The following is a description of a gene set: Mouse Gene Set: REACTOME_GLI3_IS_PROCESSED_TO_GLI3R_BY_THE_PROTEASOME species: Mus musculus GLI3 is processed to GLI3R by the proteasome, and this is the list of marker genes: Psmc1, Ubc, Rbx1, Psmc5, Uba52rt, Psmd11, Psmc3 (NCBI Gene Id 19182), Psmd2, Psmb4, Psma2, Psmd14, Skp1, Psmb1, Psmd6, Psmd13, Ubb, Csnk1a1, Psmb6, Psmb2 (proteasome (prosome, macropain) subunit, beta type 2), Psmc6, Psmd8, Prkacb, Psmc4, Psma4, Psma6, Psmd1, Adrm1, Rps27a, Psma1, Psma5, Prkaca, Psma3, Gli3, Psma7, Sufu, Psmb3, Gsk3b, Cul1 (NCBI Gene Id 26965), Psmb5, Psmd7, Psmd12, Psmc2, Uba52, Psmd3, Psmb7